Given this list of marker genes CFAP300, DNAJC30, GCH1, CYP27B1, DAG1, WDR19, MMP2, TELO2, GBA1, RPL8, CLCN5, TNNT3, CHST3, TNNI2, IFT56, PRIM1, FANCE, EIF4A3, EOGT, PACS2, PYROXD1, FLT4, FTO, PHOX2A, CUL3, TGFB2, GUSB, SH3PXD2B, RIPPLY2, COMT, KIAA0753, BTRC, CHRNA1, BMP6, RB1, B3GALNT2, NRAS, BBS5, GJA5, POLR3A, LETM1, NARS1, CITED2, PEX7, SDHC, ALG6, MKS1, EXTL3, HNRNPH2, WDR62, GFM2, SVBP, RNU4ATAC, KIF7, CEP55, GABBR2, UFD1, CFAP298, SACS, CYP19A1, NEK10, KCNH1, HIVEP2, SMC5, FBXO28, EGR2, MPLKIP, IARS2, CDC45, ANKH, EED, APC2, MYL11, SLC35A2, SEC24D, STK36, CNTNAP1, MEGF8, DDX59, TMEM147, HSPB1, PRDM5, ARMC9, NT5C2, PDZD8 (NCBI Gene Id 118987), FGFR1, PWRN1, SLURP1, CTNND2, MIR17HG, SEM1, DCAF8, KAT6A, KDM6B, SMAD3, SHANK3, CHSY1, PUM1, TMEM53, CRB2, GTF2E2, SLC39A8, MAN1B1, SLC2A2, RPL15, ATR, WDPCP, DNM1L, NEFL, DOK7, METTL27, WDR11, C1R, EHMT1, ZEB2 (NCBI Gene Id 9839), PRG4 (proteoglycan 4), JPH1, FAM20C, MIR140, NF1, CTU2, STK11, CHCHD10, SOX11, EDA, RPL18, ADNP, NOTCH1, TSHR, PNKP, GABRG2, EZH2, CARS1, RPS19, HFE (homeostatic iron regulator), FGF13, POU1F1, PAFAH1B1, FOXA2, PPP1R21, KCNJ8, TNFRSF11B, FAM13A, NLRP1, CHD1, ATP2B1, ADAMTS17, ATRIP, TG, RAB34, RAP1B, PTRH2, SLC32A1, CHRNA7, KMT2D, PAH, SC5D, ARCN1, GH1, CDAN1, RNU12, NEB, RAD21, EXOC6B, JARID2, TLK2, TMEM237, MKRN3, SKIC3, PRKACB, TRAF3IP1, ATP11A, GPKOW, PROKR2, AMMECR1, MAPK1, FGD1, COL6A3, SMARCD2, RDH11, EXOSC5, SLC2A10, WDR73, MYOD1, FBXO11, DUOX2, HYLS1, MET, OTUD5, SVIL, CHRND, H3-3A, RAPSN, GON7, DNAI2, FRA10AC1, PIGG, KAT6B, CYP2R1, ZMYND10, MTFMT, CLCF1, RBM10 (NCBI Gene Id 8241), ATP6V0A2, PLOD3, ZDHHC9, ARL13B, KRT16, GNE (NCBI Gene Id 81868), ERI1, ANKRD55, CRIPT, GNPAT, ITGB6, SOX6, RPS28, MEF2C, SPECC1L, BTNL2, PPP1R12A, DOCK6, FANCI, CHD7, SPEG, CCN6, FANCD2, LAMB3, MYRF, DHCR24, L1CAM, IDH2, CKAP2L, PTHLH, MMP14, ORC1, CBL, CIBAR1, FAT4, TAF1, MEG3, BBS4, MEGF10 (multiple EGF like domains 10), SCARB2, SEMA5A, MSL3, CRELD1, KIF5C, PIGY, RAB18, LMBR1, GJB3, PIGN, RPL35A, TAF4, HSPG2, SMARCAL1, IQSEC2, PAPSS2, VDR (NCBI Gene Id 7421), ASXL2, MAF, PACS1, MARS1, TRAIP, HIC1, NOTCH2, ACTA2, GDAP1, CTC1 (CST telomere replication complex component 1), SFTPA2, HOXA13, SLC35B2, CCDC40 (coiled-coil domain 40 molecular ruler complex subunit), CILK1, CRKL, HDAC4, CAMK2G, TFAP2A (transcription factor AP-2 alpha), BAZ1B, TRIO, PHEX, PIGP, GLI2, NDRG1, LOX, CHUK (NCBI Gene Id 1147), EDA2R, WRN, CDC42BPB, ALG9, POLE, BMPR1A, CRPPA, MTOR, ACTB, B3GLCT, DKC1, AMER1, TRIP13, RAC1, NEDD4L, DDX11, UQCC2, AHI1, TOR1AIP1, BICD2 (NCBI Gene Id 23299), ATP6V1E1, GTF2IRD1, FANCG, PPP2R1A, ACVRL1, EMC1, CFAP221, RPL10, PLCB3 (NCBI Gene Id 5331), TOPORS (NCBI Gene Id 641432), ACTG2, TBX15, GDF6, RNF113A, KCNK9, RREB1, MAN2C1, MED12, COL1A2, TPM2, DYNC2H1, BICRA, ESCO2, KIFBP, SDHD, ARID1A, DYNLT2B, GABRA1, CEP19, GNAS-AS1, IL2RG, PIK3CD, SCN4A, RETREG1, PAK3, IFITM5, FKBP6, PLAA, AXIN1, PPP3CA, TERT, DLX3, GLA, COL4A1, ASXL3, HYAL1, GABRD, TGFB1, TBX4, MCIDAS, SPRED1, DLX6, TPO, ATP6V1B2, RPL13, INTS8, CYP27A1, HNRNPK, TUBB2B, DLG4, COL5A1, RSPH1, RAI1, PTPN2, GJA8, SMO, SGMS2, GABBR1, ALDH6A1, CIITA, BBS9, INPP5E, HEPACAM, SLC25A12, SYNE1, TCIRG1, BUD23, PMP22, CFAP418, RSPO2, TCF20, LRSAM1, WBP4 (WW domain binding protein 4), PMM2, DLL3, ABCA3, RPL31, DNAH11, DNMT3A, IDS, KIF15, KCNK4, MECOM, RTEL1, NARS2, LEMD2, SMS, BPTF, NTNG1, FDFT1, WNT3, SYT2, TXNDC15, CSNK2A1, NEK1, PIGO, NR2F1, RAB23, EPB41L1, PIK3R1, NCF1, RPS23, PURA, IL6ST (NCBI Gene Id 3572), CNOT3, ZNF292, KDM5A, AIFM1, CCDC32, VPS13B, BRIP1, TMEM218, IFT172, EPS15L1, NEPRO, NEK9, MALT1, ADGRG6, CACNA1C, BBS10, G6PC3, SLC25A22, PCGF2, RPL5, IDH1, BRCA2, BMS1, FCGR2A, CDIN1, DMXL2, SP7, GATA6, RPL11, ADAMTSL1, EHHADH, MRPS16, NPR2, AUTS2, TGFBR1, SLC6A1, TP63, GNAI1, UFSP2, FBN2, FLI1, ZSWIM7, BMP4, HYOU1, KCTD1, TMEM94, PARN, ARVCF, FAH, KCNE5, POLR1A, RUSC2, B3GAT3, ARSK, COX7B, SCNN1G, YRDC, SKI, RFX7, SUMF1, CFAP74, KDM5C, TLL1, ARX, LTBP3, PEX5, B9D2, IFT80, PDE3A, MESP2, SLCO2A1, CHD2, RECQL, ENG, CD247, POLA1, KRT10, PRKAR1B, FIG4, ITGB4 (NCBI Gene Id 3691), SLC25A46, EN1, GHR, PIGW, CDKL5, NSUN2, KDM5B, OTX2, TRIM8, WIPI2, CRLF1, NPHP1, MPZ, RPS29, MYCN (MYCN proto-oncogene, bHLH transcription factor), COL9A2, TFE3, NKX2-5, NME5, BBS1, SON, FBXL3, CTCF, SPART, SLC26A2, NONO, GATA2, ZNF469, WNT7A, HADHA, CTNS, MBTPS1, LZTFL1, DNAAF2, MYSM1, KMT5B, DEAF1, DNAAF1, TENT5A, RRAS2, CAMSAP1, SFRP4, MYH3, DPM1, PSMB4, RHBDF2 (NCBI Gene Id 79651), ALG13, EIF2AK3, PHGDH, FANCA (FA complementation group A), HDAC8, EIF2S3 (NCBI Gene Id 8422), FANCM, NEXMIF, PRDM16, KIF21A, REEP1, ARPC4, ITGA7, KCNA1, CCBE1, OCRL, WAC, SPAG1, CEP57, NKX3-2, HOXD10, SLC10A7, NAA60, EXOSC9, NAA10, CNOT1, DPH2, KRAS (KRAS proto-oncogene, GTPase), TCF12, EXT1 (exostosin glycosyltransferase 1), SPARC, FANCB, ROR2, IFT122, POMT2, USP9X, NSD2, MAP2K2, CBS, NCKAP1L (NCBI Gene Id 3071), SIK3, UBE3C, CD244, POMK, DPP9, NIN, MYBPC1 (myosin binding protein C1), HERC1, NPHP3, GNPTG, KDELR2, KCNN3, AEBP1, SERPINH1, SCARF2, RPS6KA3, RNF6 (ring finger protein 6), FGFR3, TRRAP, HSPB8, COL2A1, UBA2, WDR35, WNK3, OSGEP, PITX1, ADA2, DNAAF5, MBTPS2, TOMM7, ARID1B, ALG8, COPB1, AKT1, B4GAT1, SMC3, BLM, FAM50A, ODAD4, NSMF, PPM1D, INF2, FBLN5, SPTBN1, SSR4, PRKCZ, RAD51, XYLT2, NLRP3, KDM4B, PIEZO2, UFC1, ACP5, SELENON, OCA2, SMPD4, ITPR1, SCAF4, ANO5, SMARCB1, UBR7 (ubiquitin protein ligase E3 component n-recognin 7), OTUD6B, JUP, TBL2, DLK1, SRP54, GJB4, CERT1, DCPS, UBA1, GNPNAT1, TWIST1, COX4I1, PEX2, KCNJ2, MAD2L2, LARS1, SEC24C, TUBB3, NELFA, AHSG, PDPN, ALX3, H4C3, TAF6, EXT2, NR5A1, GDF1, HES7, DHCR7, SLC9A6, GLI3, LARGE1, RTL1, BCORL1, GTF2I, CPLX1, TBCE, MMP9, STN1, IQCE, FREM2, RPS10, COG1, SLC22A4, SLC25A24, LFNG, IDUA, PEX1, HNRNPA1, DNAAF6, DNAAF4, SFTPC, CSPP1, EIF2AK4, KPTN, RPS17, FGF23, ALPL, SRCAP, SPEF2, SCNM1, CHST11, NBAS, SALL1, SH2B1, JAG1, DNAAF11, KMT2A, SLC5A5, BMPER, NUP88, SBF1, SDCCAG8 (NCBI Gene Id 10806), BPNT2, LMX1B, NKAP, BRD4, ATP6AP2, TBC1D7, RASA1, POC1A, PTH1R, VPS35L, RFWD3, SOS2, GBF1, TRAPPC9, DNAJB13, BMPR1B, CA2, NOTCH3, LAMC2, IL21, STX1A, UBE4B (ubiquitination factor E4B), NAA20, PDGFRB, SLX4, BBIP1, DACT1 (NCBI Gene Id 51339), SMARCA2, SIGMAR1 (NCBI Gene Id 80768), DMP1, SMARCE1, PALB2, RET (ret proto-oncogene), P3H1, SLC4A10, NOG, ATRX, KCNJ5, TBX22, PKDCC, CHP1, CEP120, GORAB, DNAH9, ASCC3, COASY, TBC1D2B, MOGS, RHOA, ADAT3, ALMS1, RYR3, RAB3GAP2, FBLN1, TRAPPC2, UBR1, TMEM67, DSP, PRRT2, SNORD116-1, PSAT1, PTPN11, FMR1, TTC21B, KLLN, MTAP, DPYS, SPIDR, VPS33A, SCUBE3, HS6ST1, RASA2, XRCC4, MTX2, SIN3A, ZIC1, IPO8, EXOSC2, TPM3, IRF1, ERGIC1, TCTN1, EVC, ASXL1, RFT1, HEPHL1, TOR1A, COLEC11, DNAJC21, NSD1, PHLDB1, GNA11, RPGR, NEK8, TBC1D24, CCDC47, WASHC5, MIA3, LPIN2, ARHGAP31, TBCK, DUOXA2, CD55, COG8, IHH, PCYT1A, B4GALT7, PROP1, CPT1C, BBS2, TRMT5, DYNC2LI1, KATNIP, TTI1 (NCBI Gene Id 9675), INSR, IFNGR1, CDH1, TXNL4A, RPL27, ERCC6, IFT81, DNAH5, ERCC3, ORC6, SMARCA4, PIGQ, GNB4, ENPP1, PSMD12, MAGEL2 (NCBI Gene Id 54551), DPH1, SPTAN1, IGF1R, VCP, RINT1, CBY1, CCDC28B, LHX4, RBPJ, GARS1, PPP1CB, HESX1, MTR (NCBI Gene Id 4548), RAB11B (NCBI Gene Id 9230), TMCO1, PTPN22, ERMARD, OPA3, COL1A1, NECTIN1, DPAGT1, LHX3, RPL35, SETD1B, TMEM231, SLC18A3, REV3L, MPV17, EFEMP1, KRT9 (NCBI Gene Id 3857), B9D1, CDC6, TNFRSF11A, NSDHL, ERF, SUFU, STUB1 (NCBI Gene Id 10387), WLS, SHOX, C2CD3, ACBD6, ACVR1, POGZ, DPF2, DRC1, KIF26A, RPL26, ATG7, HOXD13, CDK13, RNU4-2, FGF10, DDX6, ALDH18A1, TRIM32, DNAH1, SOD1, COL10A1, BMP1, KIAA0586, SLC35A3, COL12A1, DSE, GLE1, PPOX, SLC35A1, HEATR3, ALDH1A2, ORC4, TSHB, RAB33B, MTHFS, TNFSF11, PRKDC, SFTPA1, SLC16A2, NFIX, ANAPC1, NCAPG2, SNRPB, FREM1, CHD4, TBXAS1, SRY, TSR2, PIGK, DYM, TTI2, BMP15, FOXE3, KDM1A, KMT2B, SLC31A1, BBS7, CCDC88A, ZFX, UBE3A, GNAO1, SIL1, SH3TC2, CEP164, IGF2, PIK3C2A, SEMA3E, PAX3, RERE, CTNNB1, CRTAP, MKKS, RNF13, PGAP2 (post-GPI attachment to proteins 2), ZNHIT3 (NCBI Gene Id 9326), ZBTB20, TBX1, BANF1, WASF1 (WASP family member 1), BRAF, CENPE, ANTXR2, GNPTAB, NHS, PHYH, CTSC, SAMD9, TCTN2, GATAD2B, RAB7A, FLVCR1, UBAP2L, INTS1, BNC1 (NCBI Gene Id 646), MYH8, SHH, PMP2, HHAT, CCDC8, TMEM107, STAMBP, NECTIN4, B3GALT6, SOS1, RPS26 (ribosomal protein S26), RPS7, HCN1, ACTL6B, TRIP11, CDT1 (chromatin licensing and DNA replication factor 1), BAP1, KDR, BIN1 (NCBI Gene Id 274), UNC80, TDO2, TFAP2B, IYD, CWF19L1, ALG12, GPR101, MATN3, FLII, NFASC, KCNAB2 (NCBI Gene Id 8514), MFAP5, PYCR1, CDK10, TGDS, PDE4D, IGHMBP2, BRCA1, VAC14, C12orf57, FIBP, MED12L, SATB1, TMEM38B, ZSWIM6, HSD17B4, SETBP1, B2M, SPRED2, SOX5, SMAD4, DLEC1, PSAP, GRM7, POP1, AGA, SCNN1A, DVL3, GLMN (NCBI Gene Id 11146), ALX1, MEIS2, POLR3GL, H19, MACROH2A1, UBE2T, PORCN, SPRTN, CACNA2D1, NEU1, OGT, COL11A1, ARSL, DPH5, PLAAT3, MADD, CSGALNACT1, GABRA3, ACSL4, IGF1, STX1B, TONSL, PRMT7, PWAR1, NKX2-6, ZFPM2, PI4KA, CLIC2, SHOC2, FUCA1, EFEMP2, SYT1, NAA80, TYMS, GMNN, SCN1B, MORC2, AARS1, RIGI, GP1BB, LTBP2, SLC39A13, ACTA1, HPGD, SIAH1, THOC6, PTF1A, IL2RB, PNPLA6, LSS, DOCK3, YWHAE, HNRNPR, CC2D2A, TRIP12, SLC35D1, SCYL2, IMPDH2, FN1, SIK1, CTSK, AFF3, COL3A1, CDH3, CWC27 (CWC27 spliceosome associated cyclophilin), EIF4A2, SPOP, EMG1, SYNGAP1, RPGRIP1L, DPYSL5, KATNB1, KAT8, DLG5, IRF6, LUZP1, PCDHGC4 (protocadherin gamma subfamily C, 4), KIAA0825, FGF16, COL25A1, PDE6D, ROBO1, TGFBR2, CREB3L1, NOD2, TTN, RUNX2, GPC3, CCND2, SOST, ASPH, SUPT16H, GDF5, GAS2L2, PUS3, ALX4, DHODH, ITPR3, SETD5, NDN, RSPRY1, RAG1, ATP13A2, ARSB, CYP3A4, IARS1, AGPS, SOX9, RIN2, DNAL1, MYLK, LEMD3, RRAS, ACAN, MAT2A (methionine adenosyltransferase 2A), ALOX12B, ZMPSTE24, USF3 (NCBI Gene Id 205717, upstream transcription factor family member 3), LAMA3, SLC12A2, SCN2A, PAPPA2, CANT1, COG4, COA7, MAN2B1, GLB1, PIGT, PIGL, KLF13, RXYLT1 (ribitol xylosyltransferase 1), FAM149B1, PGAP3, GRIN1, TASP1, ZC4H2, PAICS, USB1, NFKBIL1, FHL1, TMEM270 (NCBI Gene Id 135886), LRP5 (LDL receptor related protein 5), FBXW11, BLTP1, GJB6, CPT2, MMP13 (matrix metallopeptidase 13), ASAH1, ANKLE2, RTN2, VPS51, FOXJ1, NPR3 (natriuretic peptide receptor 3), NUP85, ALOXE3, FZD2, ERCC8, HBB, NALCN, ODC1, GLDN, SUCLG1, MUC5B, ADCY6, DCHS1, ARL3, FKRP, RAC3, ZNF423, PEX6, BMP2, RFC2, THSD4, TMEM260, CDKN1C, PCDH19, ATAD1, TMEM70, LAMA5, FKBP10, COL9A3, CEP104, PIGB, GALNS, DHPS, DVL1, RYR1, TRPS1, CNOT2, CHD8, CDH11, EBF3, LMNB2, SLC17A5, ARL6IP6 (NCBI Gene Id 151188), KDSR, DNA2, PPP2R5D, PIGA, MAPRE2, PAM16, PIK3CA, PLK4, LYSET, MTM1, BCR (BCR activator of RhoGEF and GTPase), MTRR, PPIB, ZPR1, CDC42, KIF22, TOGARAM1, SF3B4, SPEN, CAPRIN1, STXBP1, H4C9, IFT52, RIT1, PGM3, NGLY1, ATPAF2, GAN, CAPN3, ADH5, AIP, ZMIZ1, WNT4, MCM3AP, LTBP4, H4C5, SHMT2, FGFRL1, SCN9A, CAMTA1, SNX14, YY1AP1, GJA1, POR, TBR1, TARS1, COG6, TTC8, SLC34A1, ABCA12, FSHR, CCNQ, CFL2, KIF14, NDE1, ARID2 (NCBI Gene Id 57676), KMT2E (lysine methyltransferase 2E (inactive)), IL11RA, PEPD, DDR2, AHDC1, ARL6, GGCX, MECP2, HINT1, SLC9A7, TBL1XR1, KNSTRN, ALG14 (ALG14 UDP-N-acetylglucosaminyltransferase subunit), HLA-DRB1, CENPF, SLC6A9, MRAS, DYNC2I2, SLC34A2, ZMYM2, SLC5A6, CHN1, CLTCL1, ESAM, RASGRP1, TRPV4, SNORD115-1, BRF1, HIRA, SMARCD1, CSF1R, IKBKG, CACNA1G, POT1, CDCA7, IFIH1, CEP41, PDXK, IL7R, CFAP410, ADAMTSL2, SNIP1, RNF216, GPX4, LIMK1, HECTD4, LIG4, HRAS, CLCN3, BBS12, PAX1, RSPH4A, WNK1, MYH11, ATN1, RMRP, PRKAR1A, CLIP2, ODAD1, HYDIN, COMP, SFTPB, BSCL2, TRMT10A, PRR12, RPS20, CUL7, CLDN16, EFNB1, MARS2, NIPBL, FARSA, RPS24, NME8, LRRK1, PTCH1, DNAAF3 (dynein axonemal assembly factor 3), CENPT, FBXL4, RAD51C, DLL4, TPR, MAPK8IP3, SDHB, PIK3R2, RELN, BRAT1, TGFB3, CCDC39, DCLRE1C, CIC, COL6A2, WDR26, MAP3K20, PRKD1, MUSK, HERC2, SLC34A3, LRBA, FBN1, OFD1, WNT10B, MGP, SIM1, NUP188, QRICH1, KRT1, KCNJ11, HOXA11, ABL1, AFF2, PCNT, TINF2, FANCL, DYNC1H1, NBN, MFN2, OSTM1, SATB2, NR4A2, MYMK, ZIC3, IFT43, IFT27, NUP107, NRCAM, SLC6A17, PIGV, NSMCE2, CEP290, AP4M1, MMP23B, WWOX, ZNF699, TRPM3, MAP2K1, TPRKB, NDUFAF6, TCF4, PLEKHM1, TBX3, CNTNAP2, AP2M1, SEPTIN9 (septin 9), IRX5, LAS1L, POLRMT, P4HTM, NOP10, EFL1, CHD6, LTBP1, MSH4, FLNB, GNB1, SOX4, UBE3B, EIF5A, GSC, PTCH2, SCN1A, CTSD, EIF4H (NCBI Gene Id 94573), PLAG1, JMJD1C, AKT3, IFT74, STX16, PISD, UPF3B, PLOD1, NUP37, NPM1, KMT2C, SALL4, MED13L, SEC23B, TCTN3, IL10, MAFB, POMT1, ALG3, PHF21A, ABCC8, MASP1, FKTN, PRKACA, ASPN, RIPK4, FBXW4, SNX10, LRP4, BHLHA9, ZNF141, PIBF1 (NCBI Gene Id 10464), VRK1, CTDP1, MRPS22, OBSL1, CREBBP, SNRPN, DBH, MSX2, SCAPER, ADAMTS3, COL6A1 (collagen type VI alpha 1 chain), NPAP1, H3-3B, NANS, RPS15A, GRIP1, RBBP8, CHST14, PLOD2, GJB2, HTT, XRCC2, ECEL1, HEY2, KIF3B, SMARCAD1 (NCBI Gene Id 7303), TBX2 (T-box transcription factor 2), ADAMTS10, FOXP2, PLEKHG5, MGAT2, NEUROD2, CEP295, INPPL1 (NCBI Gene Id 3636), CCNO, GRB10, SLC12A6, PTEN, ATL3, SMOC1, BGN, LMNA, ATP9A, BCOR, RLIM, RPL9, PIGF, RAF1, PLXND1, PHF8, SF3B2, CYP26B1, CPLANE1, RNF2, EBP, RPS27, CCN2, PIGS, ODAD3, ADGRV1, P4HB, SCNN1B, BUB1B, GTF2H5, TWIST2, CHEK2, KL, TTC12, CTNND1, SMC1A, KIF1B, POMGNT1, DONSON, TERC, HS2ST1, CASK, SMG9 (NCBI Gene Id 56006), SERPINF1, MITF, WDR4, USP7, CCDC22, KLHL15, GATA1, RPGRIP1, XYLT1, UGP2, GALNT2, DHX30, TRPV6, SMAD2, RSPH3, TMEM216, PRX, COG7, LZTR1, DDX3X, FTSJ1, LIFR, DNAI1, DYRK1A, CEP152, WFS1, HBA2, PLEC, EVC2, PHIP, RAB3GAP1, CNTN1, AGO2, AP1G1, MAB21L2, FRAS1, STAG2, STAG1, CHRNG, TP53RK, COL11A2, DLX5, CASR, MLXIPL, SLC52A2, BUB1, ZNF668, ITCH, PIGH, WNT5A, RAG2, LBR, MAPKAPK5, FANCC, PTDSS1, RALA, HADHB, RTTN, PRKG2, FILIP1, RSPH9, WDR81, GNAS, CASZ1, ANTXR1, KLHL40 (NCBI Gene Id 131377), EP300, FERMT1, YY1, KDM6A, CLP1, WRAP53, MID2, TMEM165, CLCN7, MBD5 (methyl-CpG binding domain protein 5), IFT57, ECE1, TUBB, TMEM138, LAGE3, ABCC9, SIN3B, ACTG1, CCNK, COLEC10 (NCBI Gene Id 10584), EFTUD2, RECQL4, STAT4, IFT140, GNB2 (G protein subunit beta 2), ADAMTS15, POMGNT2, ZNF407 (NCBI Gene Id 79610), ERCC5, APC, SBF2, COL9A1, FOXP1, ANKRD11, PYCR2, TREX1, CFTR, MYMX, GATA5, COG5, TAPT1, UBE2A, CTBP1, HACD1, PUF60, FAM111A, HNRNPH1, UNC45A, MAD1L1, AFF4, MED25, EXOC7, CD96, GLI1, KRT14, MRPS28, ADA, GPC6, SLC35C1, FGF9, GTF2IRD2, ADAMTS2, LMOD3, FLNA, HBA1, NHP2, SLC2A1, PSMC3IP, VPS37D, PQBP1, DDRGK1, FGFR2, PPP1R15B, INTU, MAX (MYC associated factor X), PHF6 (NCBI Gene Id 84438), MYL2, MAP3K7, GPC4, KIF1A, SMARCC2, DYNC2I1, PPP2R3C, ACOX1, ELN, ERLIN2, SBDS, FANCF, MCTP2, BUB3, SMAD6, ARHGEF2, NXN, ATP7A, CCDC134, HSPA9, COL5A2, RBM8A, SUZ12, MAP1B, COL27A1, PSMB8, RNF31, HMGA2, LONP1, SLC29A3, LRRC56, CUL4B, SCLT1, IL2RA, ODAD2, CBFB, ERCC1, HUWE1, KLHL41, TP53, TRAF7 (TNF receptor associated factor 7), ZNF462, TUBA1A, ERCC2, HDAC6, POLR3H, ERCC4, PRKG1, TBX5, CAMK2A, GATA4, POMP, KANSL1, NUP133, HARS1, here is a description of the gene set: Human Gene Set: HP_ABNORMALITY_OF_LIMB_BONE studied in species Homo sapiens Abnormality of limb bone